Given this list of marker genes GATA4, VAMP7, AR, DHX37, NR2F2, CHRM3, ZFPM2, NR0B1 (nuclear receptor subfamily 0 group B member 1), NR5A1, MKKS, WT1, PPP1R12A, WWOX, SRY, MAP3K1, CYP11A1, SRD5A2, SOX9, here is a description of the gene set: Urogenital sinus anomaly A rare birth defect in women where the urethra and vagina both open into a common channel. species: Homo sapiens Human Gene Set: HP_UROGENITAL_SINUS_ANOMALY